The following is a description of a gene set: A membrane-bounded intracellular vesicle formed by invagination of the plasma membrane around an extracellular substance. Endocytic vesicles fuse with early endosomes to deliver the cargo for further sorting. Human Gene Set: GOCC_ENDOCYTIC_VESICLE studied in species Homo sapiens, and this is the list of marker genes: CLTB, STAB2, STAM2 (NCBI Gene Id 51453), BTC, PIK3R4, GRIA4, STON1, ANXA11, TYRP1, SMO, SH3KBP1, RAB20, SEC22B, SFTPA2, RIN1, HBEGF, RAB11FIP3, TLR9, SH3GL2, SLC48A1, HYOU1, SFTPA1, STX7, IL7R, ZDHHC5, KIAA0319, VAMP7, CLCN3, LDLRAP1, FFAR4, APPL2, WAS, CD4, TLR1, SFTA3, HPX, RABEP1, CAMK2A, CAV1, HLA-DQB1, RAB22A, FLOT2, GOLIM4, ZYX, RAB35, EGF, NRXN1, MYO6, FMNL1, DVL2, RAB11B, UBA52, RAPGEF2 (NCBI Gene Id 9693), RAB24, PTCH1, RAB11A, ATG5, SLC9A9, GPR161, FZD4, RIN2, SLC18A3, PIKFYVE, STXBP3, CD207, NCF4, WNT5B (Wnt family member 5B), EPGN, HLA-DPB1, VAMP4, SLAMF1, DRD2, CLEC4E (NCBI Gene Id 26253), HLA-DQA2, GRIA3, DAB2IP, ARF6, SGIP1, ARRB2, TGOLN2, TIRAP, DYNC1LI1, ITGB5, PLD4, PLA2G5, RAP1A, MDM2, CD74, BECN1, PLD1, VAMP8, APOB, HLA-B, RAB14, NCF1, WNT4, HLA-A, CTSS, INPP5F, PDIA3, VPS9D1, ELANE, FZD2 (frizzled class receptor 2), DLG4, RPS27A, RAB11FIP1, DNM2, RAB38, STON2, AP2A1, HBB, SYT7, CACNG3, CYBA, APPL1, RAB8B, ACTG1, AP2B1, CDC42EP2, STXBP1, HEATR5A, EHD2, RAB9B, M6PR, CPNE6, PICK1, HP, OCRL, SRGAP2, RINL, NOSTRIN, RAB39A, ATP6V0B (ATPase H+ transporting V0 subunit b), CAMK2B, PIK3C2B, AP2M1, SFTPC, TLR2, RAB13, RAC2, ATP6V0A2, HLA-DRB4, MCOLN1, WASL, TAP1, MYO1E, FCGR1BP, TF, TLR7, NOD2, HLA-DQA1, CACNG8, WNT5A, CD3G, RIN3, ANG, RAB31, LRRK2, EPS15, WNT7A, ADRB2, RAB17 (NCBI Gene Id 64284), FCGR1A, ACE2, LYN, CD163, RABGEF1, EHD4, TCIRG1, RAB43, CORO1A, SFTPD (NCBI Gene Id 6441), HLA-DRB5, HGS, IGF2R, GNLY, MYO1C, SPHK1, KIF5B, RAB34, AVPR1A, ATP6V0E1, ENTPD7, HEATR5B, PIK3C3, SLC11A1, PLEKHG5, SYT1, AMOT, WNT3A (NCBI Gene Id 89780, Wnt family member 3A), SFTPB, RAB9A, RAB11FIP4, SYT9, FLNB, ATP6V0A1, HLA-G, MTOR, UBC, SCGB3A2 (NCBI Gene Id 117156), WNT1, CACNG4, LRP1, CD36, ECPAS, LTF (NCBI Gene Id 4057), PIP4P1, APOA1, CTLA4, HVCN1, HCLS1, VPS11, HSP90B1, ANXA3, HLA-DQB2 (NCBI Gene Id 3120), SAA1, CTSL (NCBI Gene Id 1514), HLA-C, RAB5C, ATP6V0E2, GSN (NCBI Gene Id 2934), GAPVD1, RAB7A, ATP7A, LAMP2, TAPBP, ADAM8 (ADAM metallopeptidase domain 8), HSPH1, UVRAG, CD82, CLTA, WNT6, STX12, LDLR, MTMR4, ATP6V0D1, LPAR1, CSF3R, STX4, DPP4, TBC1D5, FZD5, AREG, HSP90AA1, ARRB1, AP2S1, ITGAV, WLS (NCBI Gene Id 79971), DYSF, HYAL2, RAB5A, COLEC12 (NCBI Gene Id 81035), NOD1, HBA2, MTSS1, SYT2 (NCBI Gene Id 6858), IRGM, CLTC, STX6, LMBRD1, PICALM, WNT3, HLA-E, EGFR, CUBN, SPARC, TFRC, HLA-DPA1, LRP2, MPO, ABCA1, AVP, CAMK2G, RAB32, CSF3, UNC93B1, RILP, STX8, SLC15A2, APOE, EREG, CDC42EP4, STXBP2, CTTN, HLA-DRB1, TGFA, NLGN3 (NCBI Gene Id 54413), HLA-DRA, VAMP2, SCARB2, INPP5B, B2M, GRIA1 (NCBI Gene Id 2890), CDC42, ATP6V0A4, ATP6V0C, PGLYRP1, RALA, RAB11FIP5, DNM1, HLA-H, SYT11, RAB8A, MSR1 (NCBI Gene Id 4481), MARCO, SLC2A8, TRIM14, ROR2, ATP6V0D2, CFTR (NCBI Gene Id 1080), AVPR2, MPEG1, CLTCL1, VAMP3, VIM, SYK, OCLN, PIP4P2, CD9, LPAR2, STXBP4, TLR6, SCARF1, CD3D, RAB23, STAB1, CHRM2, VPS26B, SCIMP, HLA-DRB3, EHD3, NOS3, EHD1, NCF2, RAB7B, AMBRA1, RAB5B, UBB, LAMP1, DMBT1, GRIA2, CALR, AMN, SNX3, CACNG2, ATG12, AP2A2, RAPGEF6, HLA-F, BTBD8, WNT7B, SCARB1, SNAP23 (synaptosome associated protein 23), RAB10, CAMK2D, CYBB, CEMIP, TAP2, HBA1, AMELX, ATG14